The following is a description of a gene set: The process whose specific outcome is the progression of the third ventricle over time, from its formation to the mature structure. The third ventricle is the narrow cleft inferior to the corpus callosum, within the diencephalon, between the paired thalami. Its floor is formed by the hypothalamus, its anterior wall by the lamina terminalis, and its roof by ependyma, and it communicates with the fourth ventricle by the cerebral aqueduct, and with the lateral ventricles by the interventricular foramina. Mouse Gene Set: GOBP_THIRD_VENTRICLE_DEVELOPMENT studied in species Mus musculus, and this is the list of marker genes: Dpcd, Myh10, Atp1b2, Kdm2b, Grcc10